The following is a description of a gene set: Galactose catabolism Mouse Gene Set: REACTOME_GALACTOSE_CATABOLISM studied in species Mus musculus, and this is the list of marker genes: Gale, Galm, Galk1, Galt, Pgm1